Given this list of marker genes HLA-DPA1, CLC, DEK (NCBI Gene Id 7913), IGLV2-14, RNASE2, HMGB1, MS4A3, HLA-DMA, SYK, GPR183, MYB, CPA3 (NCBI Gene Id 1359), HLA-DRB1 (NCBI Gene Id 730415), here is a description of the gene set: from publication Gutiérrez NC, Ocio EM, de Las Rivas J, Maiso P, Delgado M, Fermiñán E, Arcos MJ, Sánchez ML, Hernández JM, San Miguel JF (PMID 17252022) studied in species Homo sapiens Human Gene Set: GUTIERREZ_WALDENSTROEMS_MACROGLOBULINEMIA_2 The tumoral clone of Waldenström's macroglobulinemia (WM) shows a wide morphological heterogeneity, which ranges from B lymphocytes (BL) to plasma cells (PC). By means of genome-wide expression profiling we have been able to identify genes exclusively deregulated in BL and PC from WM, but with a similar expression pattern in their corresponding cell counterparts from chronic lymphocytic leukemia (CLL) and multiple myeloma (MM), as well as normal individuals. The differentially expressed genes have important functions in B-cell differentiation and oncogenesis. Thus, two of the genes downregulated in WM-BL were IL4R, which plays a relevant role in CLL B-cell survival, and BACH2, which participates in the development of class-switched PC. Interestingly, one of the upregulated genes in WM-BL was IL6. A set of four genes was able to discriminate clonal BL from WM and CLL: LEF1 (WNT/beta-catenin pathway), MARCKS, ATXN1 and FMOD. We also found deregulation of genes involved in plasma cell differentiation such as PAX5, which was overexpressed in WM-PC, and IRF4 and BLIMP1, which were underexpressed. In addition, three of the target genes activated by PAX5 - CD79, BLNK and SYK - were upregulated in WM-PC. In summary, these results indicate that both PC and BL from WM are genetically different from the MM and CLL cell counterpart. Genes exclusively up-regulated in B lymphocytes from WM (Waldenstroem's macroglobulinemia) but with a similar expression profile in MM (macroglobulinemia) and normal cells.